Given this list of marker genes D630024D03Rik, Gm12123, Hba-x, Mir103-1 (NCBI Gene Id 723824), Lcp2, 4930555O08Rik, Gm12103, Mpg, Gm12126, Stk10, Nprl3, Hba-a1, Gm12108, Asb3 (ankyrin repeat and SOCS box-containing 3), Gm12121, Gm12104, Rhbdf1, Smim23, Bod1, Gabrp, Rars1, Gm26070, Gpr75 (NCBI Gene Id 237716), Snrnp25, Nsg2, Stc2, Hbq1a, Acyp2 (NCBI Gene Id 75572), Gm12118, Dock2, Gm12100, Fbll1, Rpsa-ps4, Gm22022, Gm12117, Gm12097, Il9r, Kcnmb1, Fbxw11, Gm12101, Gm12098, Pank3, Gm8192, D130052B06Rik, Gm12111, Foxi1, Ranbp17, Cpeb4, Mir218-2, Wwc1, Gm12109, Psme4, Erlec1, Gm12107, Gm12099, Sh3pxd2b, Anp32-ps, Hba-a2, Hbq1b, Gm12110 (predicted gene 12110), Gm12711, Gm12096, Gm12125, 4930403D09Rik, Ubtd2, Gm12102, Slit3, 4930505A04Rik, Tlx3, Gm12119, Kcnip1, 4930524B15Rik, Npm1, Insyn2b, Gm12115, 4930469K13Rik, Fgf18, Spdl1, Efcab9, Chac2, here is a description of the gene set: studied in species Mus musculus Mouse Gene Set: chr11A4